Given this list of marker genes IK, MTBP, AURKB, TRAPPC12, RCC2, ZWILCH (zwilch kinetochore protein), CENPQ, TTK, ZW10, CDK1, SPDL1, CHAMP1, KNL1, KNTC1, BUB3 (NCBI Gene Id 9184), here is a description of the gene set: A process in which a protein is transported to, or maintained in, a location within a condensed chromosome. Human Gene Set: GOBP_PROTEIN_LOCALIZATION_TO_CONDENSED_CHROMOSOME studied in species Homo sapiens